The following is a description of a gene set: Defective factor VIII causes hemophilia A studied in species Homo sapiens Human Gene Set: REACTOME_DEFECTIVE_FACTOR_VIII_CAUSES_HEMOPHILIA_A, and this is the list of marker genes: VWF, F9, TPST1, F10, F8, TPST2, F2